The following is a description of a gene set: studied in species Homo sapiens Human Gene Set: DISTECHE_ESCAPED_FROM_X_INACTIVATION from publication Disteche CM, Filippova GN, Tsuchiya KD (PMID 12900543) Although the process of X inactivation in mammalian cells silences the majority of genes on the inactivated X chromosome, some genes escape this chromosome-wide silencing. Genes that escape X inactivation present a unique opportunity to study the process of silencing and the mechanisms that protect some genes from being turned off. In this review, we will discuss evolutionary aspects of escape from X inactivation, in relation to the divergence of the sex chromosomes. Molecular characteristics, expression, and epigenetic modifications of genes that escape will be presented, including their developmental regulation and the implications of chromatin domains along the X chromosome in modeling the escape process. Genes that escape X inactivation., and this is the list of marker genes: USP9X, TMSB4X, PRKX, UBA1, DDX3X, KDM5C, EIF2S3, STS, TBL1X, EIF1AX, RPS4X, ZFX, KDM6A